Given this list of marker genes CTDP1, MORC2 (MORC family CW-type zinc finger 2), SLC52A2, EOGT, MCM3AP, BSCL2, LSS, CPLX1, MPZ, FGFR3, HMGA2, NELFA, DHCR7, NXN, AHSG, ROR2, UBA2, TBX5, FBXW4, TCTN3, HNRNPA1, RBPJ, EPS15L1, FGFR2, BHLHA9, NDRG1, JPH1, CDKN1C, LETM1, TP63, PMP22, PIGG, DLX5, DLL4, MED12, FGFRL1, NSD2, DLX6, MAP3K20, WNT7A, BTRC, FGFR1, EGR2, ITGB6, ARHGAP31, PRX, GLI3, PORCN, HINT1, GNPTAB, SEM1, MMP2, ARSB, DOCK6, GDAP1, CTBP1, CTSD, IRF6, WLS, CDH3, NOTCH1, DLG5, SVBP, NEFL, WNT10B, MBTPS2, PLAG1, SBF2, IGF2, HSD17B4, IDS, here is a description of the gene set: A condition in which middle parts of the hands and/or feet (digits and meta-carpals and -tarsals) are missing giving a cleft appearance. The severity is very variable ranging from slightly hypoplastic 3rd toe/fingers over absent 2nd or 3rd toes/fingers as far as oligo- or monodactyl hands and/or feet. Human Gene Set: HP_ECTRODACTYLY Ectrodactyly studied in species Homo sapiens